Given this list of marker genes MEIS2, SIGIRR, LRIG3, DPP10, LASP1NB, NEURL1B (neuralized E3 ubiquitin protein ligase 1B), SLC8A1, SMOC2, CDYL, CADM4, TCEAL5, ACTR1B, SMYD3 (NCBI Gene Id 81838), JUP, PINK1 (PTEN induced kinase 1), CRABP2, H2BC12, TRAF4, TBC1D9, PEG3 (paternally expressed 3), ST6GALNAC5 (NCBI Gene Id 81849), BEX2, FMNL2, RNF207, JPH4, GPR37, IGSF3, LINC02381, NKX6-1, NRXN1, STAT4, FIBIN, SERP2, RARB, LINC00665, NET1, TRIOBP, CDH3, NPDC1, GLP2R, KCNIP1, TENM4, TMEM178A, IQGAP2, PNMA8A, HOXA4, DLG2, DOK4, ZFHX4, TMTC2, PLCE1, MID1IP1 (NCBI Gene Id 58526), TRAF5 (TNF receptor associated factor 5), IQCA1, SLC38A1, CDC34, LRRC8D, TLE4, CA11, FGF7, CTXN1, ZNF703, RDH10 (retinol dehydrogenase 10), EYA2, ZNF362, TUBB2B, FBN2, TRIO, NKAIN3, TWIST2, HAND2, CARMN, ENC1, DPY19L2, PODXL2, CNN1, SCUBE3, AKR1C1 (NCBI Gene Id 9418), IER5, RGMA, AKIRIN1, ANXA3, GAS2, HSPA12A, NRG1, DHRS3, DNAH14 (dynein axonemal heavy chain 14), AIF1, COLEC11, PDXP, ZFAND2A, CD47, BST2, FUCA1, KCNS3, SRSF8, GAP43, IRF1, FLNB, AHDC1, KIT, PHLDB2, GALNT9, FLRT3, RAC2, MDFIC, LMOD1, OCIAD2, GPSM3, BCL11A, LY6H (lymphocyte antigen 6 family member H), MYOCD, COL23A1, TPBG, NCALD, CLSTN3, TWIST1, RAB33A, GABRA2, TES, GPC4, TM7SF2, VSIG10L, KRT8, HHIP, ADAMTS8, RSPO3, BNC2, DKKL1, SLC2A8, CGNL1, PDGFC, ACTG2, OLFML2B, EPHA3, CCNQ, IGFBP2, MSC-AS1, CFAP68, DUSP5, SOWAHC (NCBI Gene Id 65124), NTM, TLL1, TENM3, KIF26B, SULF2, ANKRD29, FAM118B, SLC2A13, ANK3, EFEMP1, GLIPR1, FOXP2, DNAJC12, RHOD, ASPN (NCBI Gene Id 54829), FRZB, LEF1, ROGDI, CACNB3, HPSE2, PLCL1, RBPMS2, SEC11C, PRKAR2B, SLC25A33, FRAS1, GFRA1, PDLIM4, MXD1, TACC2 (NCBI Gene Id 10579), DNAAF5, EPHB3, RNF150, FHL2, ECHDC3, UCP2, MSC, DOCK9, NCOA7, PAPLN, TIPARP, SORBS1 (NCBI Gene Id 80057), DEAF1, CXXC4, HUNK, BEX1, EDN3, ZEB1, ANKS1A, SEL1L3, ADCY5, DEDD2, SCHIP1, PBX2, MSRA (NCBI Gene Id 4482, methionine sulfoxide reductase A), DUSP14 (dual specificity phosphatase 14), FBXO22, CD74, SLC35G1 (NCBI Gene Id 159371), IGF1, CHRM3, LRRC3B, TSTD1, NTF3, THNSL2, GFPT2, TRPM4 (NCBI Gene Id 8184), HMGA2, ASAP2, ECHDC2, EPHA4, MBP, IRAG1, DIPK1B, JAZF1, PDE3A, TMEM63B, EFNB2, PSD, CTH, PDE1A, TSPAN2, RGMB, BICD1, ALDH1A3, SGK1, NSG1, CYTH1, SCG5, EFNA1, C12orf75, FRMD6-AS2, ITM2A, LDB2, PDXK, TRAF3IP2, HHIP-AS1, PTGIS, FOXP4, SYNGR2, CD24, C3orf70, CTHRC1, AKR1C2, TNFRSF21, RAMP1, ADAMTS19, FLNC, RASL11B, ITGA5, CUEDC1, STRA6, PAWR, IL1RAPL1, BMP7, LIMS2, SYNM, SPSB1, INTS6L, ANO1, KRT18, CNTN4, COL26A1, DCX, CLUL1, NR2F6, CNTNAP3B, SIPA1L2, VIPR2, PLEKHA1, PPP2R5B, CSRP2, BCAN, PITX2, MADCAM1 (NCBI Gene Id 8174), PDZD2, FCHSD2, HSD17B14, ETV6, ADRB3, TMEM186, CDH8, RALGPS2, DMKN, TOX, B3GALNT2, BCO2, ELOVL6, MAPK10, XIST, CASC15, MCC, KRT19, here is a description of the gene set: Mesenchymal 1 Human Gene Set: HE_LIM_SUN_FETAL_LUNG_C0_MESENCHYMAL_1_CELL from publication He P, Lim K, Sun D, Pett JP, Jeng Q, Polanski K, Dong Z, Bolt L, Richardson L, Mamanova L, Dabrowska M, Wilbrey-Clark A, Madissoon E, Tuong ZK, Dann E, Suo C, Goh I, Yoshida M, Nikolić MZ, Janes SM, He X, Barker RA, Teichmann SA, Marioni JC, Meyer KB, Rawlins EL (PMID 36493756) species: Homo sapiens